The following is a description of a gene set: studied in species Homo sapiens Human Gene Set: GOBP_SYNAPTIC_VESICLE_LOCALIZATION Any process in which a synaptic vesicle or vesicles are transported to, and/or maintained in, a specific location., and this is the list of marker genes: SNAPIN, AP3M2, BTBD8, SYNDIG1 (synapse differentiation inducing 1), DNM3, MX2, MAP2, CDK5, BSN (NCBI Gene Id 90068), KIF5B, PTEN, CTBP1 (NCBI Gene Id 1487), SLC2A4, RAB3A, SYN1, PCLO, NLGN2, AP3M1, BLOC1S3, BLOC1S2, LIN7C, BRSK1, NLGN1, AP3B2, PCDH17, AP1G1, DTNBP1, PINK1, KIFC2, CTNNB1 (NCBI Gene Id 1499), SPG11, NRXN1, BORCS5, KIF5C, DNM1, RAB27A, MX1, AP3B1, CDH2, TMEM230, TRIM46, BLOC1S6, BLOC1S4, KIF1B, SYNJ1, AP3D1, SYN3, BLOC1S5 (NCBI Gene Id 63915), SNCA, LIN7A, AP3S1, BLOC1S1, SYN2 (synapsin II), DNM2, KIF5A, LRRK2, PRKN, PDZD11, BRSK2, LIN7B, TOR1A, AP3S2